The following is a description of a gene set: Mouse Gene Set: BAKER_HEMATOPOIESIS_STAT3_TARGETS STAT3 targets in hematopoietic signaling. Hematopoiesis is the cumulative result of intricately regulated signaling pathways that are mediated by cytokines and their receptors. Proper culmination of these diverse pathways forms the basis for an orderly generation of different cell types. Recent studies conducted over the past 10-15 years have revealed that hematopoietic cytokine receptor signaling is largely mediated by a family of tyrosine kinases termed Janus kinases (JAKs) and their downstream transcription factors termed STATs (signal transducers and activators of transcription). Aberration in these pathways, such as that caused by the recently identified JAK2V617F mutation, is an underlying cause for diseases such as leukemias and other myeloproliferative disorders. This recent discovery, when coupled with the fact that STATs are activated by oncoproteins such as BCR-ABL, underscores the importance of the JAK-STAT pathway in both normal cellular development and disease states. from publication Baker SJ, Rane SG, Reddy EP (PMID 17934481) studied in species Mus musculus, and this is the list of marker genes: Fas, Birc5, Ccna2, Pim2, Myc, Pim1, Nsg1, Hif1a, Ccnd3, Mmp2, Ccnd1, Ccnd2, Mcl1, Bcl2, Mmp9